The following is a description of a gene set: species: Mus musculus The regrowth of axons outside the central nervous system (outside the brain and spinal cord) following an axonal injury. Mouse Gene Set: GOBP_PERIPHERAL_NERVOUS_SYSTEM_AXON_REGENERATION, and this is the list of marker genes: Tnc, Cers2, Apod (apolipoprotein D), Nefl, Tspo, Map1b, Apoa4, Mmp2 (NCBI Gene Id 17390)